The following is a description of a gene set: species: Homo sapiens Human Gene Set: GOBP_HEART_PROCESS A circulatory system process carried out by the heart. The heart is a hollow, muscular organ, which, by contracting rhythmically, keeps up the circulation of the blood. The heart is a hollow, muscular organ, which, by contracting rhythmically, keeps up the circulation of the blood., and this is the list of marker genes: MYH7B, KCNJ3, CACNA1D, CAV1, APELA, SREBF1, TRPC1, DSP, DES, STC1, TNNC1 (NCBI Gene Id 7134), MIR208A, PPCS, ATP2B2, KCNJ12, CALM2, DSC2, GJC3, SRSF1, RAC1, SCN10A, GJA5, SLC4A3, MYL4, CYP2J2, UCN (NCBI Gene Id 7349), MYH6, SGCZ, GPD1L, THRB, ACE, KCNA5, EDNRA, RAP1GDS1, SCN7A, ACTC1, TGFB2, P2RX4, KCNIP1, ISL1, KCNE1, TAC1, KCNE5, DLG1, MYL3, RPS6KA2, MIR1-1, KCNE2, FXYD1 (NCBI Gene Id 5348), TMEM38B, ADORA3, YAP1, IRX5, WWTR1, SCN4A, GSK3A, AVPR1A, POPDC2, OXT, GATA4, SGCD, FLNA, HCN3, NOS3, ATP2A2, KCNJ2, ADM5, SCN4B, MAP2K3, ANK2, KCNN2, KCNJ8, GSTO1, SRI, EDN2, GCH1 (GTP cyclohydrolase 1), TREX1, MIR19A, TBX5, CHRM2, ADCY10, ZNHIT1, EDN3, KCNH2, ATP2B1, EDN1, FOXN4, HCN1, SLC8A1, GJD3, MTOR (NCBI Gene Id 2476), DMD, CELF2, SMAD5, TACR3, MIR30E (microRNA 30e), HEY2 (hes related family bHLH transcription factor with YRPW motif 2), ATP1A3, JPH4 (NCBI Gene Id 84502), TNF, SGCG, PDE4B, GSTM2, SCN9A, JPH2, MEF2A, BMP10, SCN3A, SMAD7, JUP (junction plakoglobin), CAMK2D, ZMPSTE24, KCNE4, GRK2, CALM1, SCN8A, HRC, MIR92A1, GLRX3, ADA, SCN11A, GNAO1, SCN2B, JPH1 (junctophilin 1, NCBI Gene Id 56704), MYH7, HOPX, GLP1R, CACNA1H, KCNE3, GSN, SCN2A, ADORA1, HCN4, ACE2 (NCBI Gene Id 59272), RNF207, FKBP1B, TPM1, KCND3, CACNA1C, SCN1A, VEGFB, CALM3, PKP2, CACNA2D1, MIR328, NOS1, CORIN, SHOX2, ATP2B3, ATG5, AGT, NPPA, C10orf71, ADM, SLC8A3, BIN1, PLN, MIR200C, NUP155, HSP90AA1, SNTA1 (syntrophin alpha 1), SPTBN4, SOD1, GATA6, TRPM4, RNLS, EPAS1, SLC1A1, JPH3, TMEM38A, ATP1B2, PTPN1, RAMP3, TMEM161B, MC3R, MYL2, HSPB7, ZC3H12A, TTN, ATP2A3, PIK3CG, NMU, NEDD4L, RANGRF, MDM2, PRKACA, CDC42, GAA, NOX4, SRC, YWHAE, SUMO1, TBX2, ATP1A1, ATP2B4, CASQ2, ATP2A1, HBEGF, MYLK2, TNNI3, ATP1B1, GPX1, MAP2K6, TBX18, TCAP, RGS2, EDNRB, AGTR2, APLN, TNNI1, CACNB2, EHD3, FYN, FKBP1A, MYL7, FGF12, CACNA1G, ASPH, EXT1, KCNIP2, RYR2 (ryanodine receptor 2), GJC1, CHGA (NCBI Gene Id 1113), NOS1AP (NCBI Gene Id 9722), PIK3CA, TMEM65, CLIC2, NKX2-5, RGS4, KCNJ5, NPFF, ADRB1, CSRP3, DNM1L, SPX (NCBI Gene Id 80763), TH, BVES, MYBPC3, SLC8A2 (NCBI Gene Id 6543), MIR448 (microRNA 448), DRD2, EXT2, ADM2, SCN5A, DSG2 (NCBI Gene Id 1829), THRA, KCNQ1, TNNT2, PDE4D, SLC9A1, ADRA1A (NCBI Gene Id 148), AKAP9, TNNI3K, DMPK, KCND2, ADRA1B, MIR133A1, TRDN (NCBI Gene Id 10345), STRIT1, TNNI2, TMIGD3, FGF13, CAV3, SCN3B, CXADR, CTNNA3, PPP1R13L, S100A1, GJA1, SCN1B, ABCC9, MIR26A1, KCNH6, ATP1A2, IRX3